Given this list of marker genes SOD3, COX17, SCO1, CASP3, STEAP1, XAF1, PIK3CA, ADAM17, MT1B, CCND1, COMMD1, MT4, FOXO3, MT1JP, SOD1, COX11, PRNP, MT3, APP, MAPT (NCBI Gene Id 8152), STEAP4, MT2A, XIAP, ATP7B, MT1X, AKT1, FOXO1, MTF2, MT1L, SP1, MT1G, CCS, MDM2, STEAP2, ATOX1, JUN, MT1H, GSK3B, ADAM9, TP53, SLC11A2, BACE1, MTF1, SLC31A2, MT1E, STEAP3, ADAM10, APC, PTEN, ATP7A, MT1F, MT1A, SLC31A1, here is a description of the gene set: studied in species Homo sapiens Human Gene Set: WP_COPPER_HOMEOSTASIS Copper homeostasis